Given this list of marker genes SPRR3, SPINK4, KRT20, ST6GALNAC1, CTSE, SCEL, FAM83A, CEACAM6, KRT6C, KRT7, FAM3D, CTSV, MYO1A, PLA2G10, GPR87, VGLL1, DHRS9, PRR15L, KRT6A, S100A2, FGFBP1, AREG, AGR2 (NCBI Gene Id 10551), CLRN3, SPRR1B, KRT15, ANXA8L1, ANXA10, TFF3, LEMD1, TSPAN8, KRT17, SERPINB4, CST6, CYP3A7, TFF2, LYZ, VSIG2, SLC2A1, BTNL8, SERPINB3, LGALS4 (galectin 4), LY6D, TFF1, AGR3, CDH17, REG4, TNS4, here is a description of the gene set: Pancreatic cancer subtypes Human Gene Set: WP_PANCREATIC_CANCER_SUBTYPES species: Homo sapiens